The following is a description of a gene set: Mouse Gene Set: CUI_B_CELL_IL9_RESPONSE_UP Genes positively differentially expressed in cell type: B cell upon treatment with cytokine: IL-9 in mouse lymph nodes in vivo. species: Mus musculus Cytokines mediate cell-cell communication in the immune system and represent important therapeutic targets. A myriad of studies have highlighted their central role in immune function, yet we lack a global view of the cellular responses of each immune cell type to each cytokine. To address this gap, the authors created the Immune Dictionary, a compendium of single-cell transcriptomic profiles of more than 17 immune cell types in response to each of 86 cytokines (>1,400 cytokine-cell type combinations) in mouse lymph nodes in vivo. A cytokine-centric view of the dictionary revealed that most cytokines induce highly cell-type-specific responses. For example, the inflammatory cytokine interleukin-1β induces distinct gene programmes in almost every cell type. A cell-type-centric view of the dictionary identified more than 66 cytokine-driven cellular polarization states across immune cell types, including previously uncharacterized states such as an interleukin-18-induced polyfunctional natural killer cell state. from publication Cui A, Huang T, Li S, Ma A, Pérez JL, Sander C, Keskin DB, Wu CJ, Fraenkel E, Hacohen N (PMID 38057668), and this is the list of marker genes: Rmnd1, Hsp90b1, Zfyve27, Calr, Taf1c, Sdf2l1